Given this list of marker genes IL11RA, RAD21, POU3F4, SETBP1, ENPP1, COL1A1, NOG, PSMD12, SMARCA4, ABCC6, STAG2, GDF6, COL1A2, BPTF, GJB6, IDS, FOXL1, GJB2, here is a description of the gene set: An abnormality of the stapes, a stirrup-shaped ossicle in the middle ear. species: Homo sapiens Abnormal stapes morphology Human Gene Set: HP_ABNORMAL_STAPES_MORPHOLOGY